The following is a description of a gene set: Human Gene Set: GOMF_POLYSACCHARIDE_BINDING Binding to a polysaccharide, a polymer of many (typically more than 10) monosaccharide residues linked glycosidically. species: Homo sapiens, and this is the list of marker genes: PPP1R3B, FCN2, PPP1R3G, VTN, EPM2A, ENDOU, PTX3, PRG4, CLEC18B, STBD1, ENPP1, PPP1R3D, CLEC18C, CLEC7A, ENPP2, HLA-DRA, AGL, CLEC4G, PPP1R3F, PPP1R3A, GPCPD1, HLA-DRB1, REG4, PPP1R3C, CLEC18A, PPP1R3E